The following is a description of a gene set: Nitric oxide metabolism in cystic fibrosis species: Homo sapiens Human Gene Set: WP_NITRIC_OXIDE_METABOLISM_IN_CYSTIC_FIBROSIS, and this is the list of marker genes: PRMT2, PRMT1, PRMT3, NOS2, PRMT6, DDAH1, DDAH2, PRMT8, PRMT7, PRMT5, NOS1, CARM1, NOS3